Given this list of marker genes CHST11, CHST14, CHST9, UST, CHST13, CHST8 (carbohydrate sulfotransferase 8), here is a description of the gene set: Catalysis of the reaction: 3'-phosphoadenylyl sulfate + dermatan = adenosine 3',5'-bisphosphate + dermatan sulfate. studied in species Homo sapiens Human Gene Set: GOMF_DERMATAN_SULFOTRANSFERASE_ACTIVITY